Given this list of marker genes Foxp3, Lum, Cx3cl1, Serpinb7, Atp6ap2, here is a description of the gene set: Mouse Gene Set: GOBP_POSITIVE_REGULATION_OF_TRANSFORMING_GROWTH_FACTOR_BETA1_PRODUCTION species: Mus musculus Any process that activates or increases the frequency, rate, or extent of production of transforming growth factor-beta1.